The following is a description of a gene set: part of: GPCR downstream signalling electronically inferred by orthology from the curated human pathway species: Mus musculus This event has been computationally inferred from an event that has been demonstrated in another species.<p>The inference is based on the homology mapping from PANTHER. Briefly, reactions for which all involved PhysicalEntities (in input, output and catalyst) have a mapped orthologue/paralogue (for complexes at least 75% of components must have a mapping) are inferred to the other species. Reactome Pathway: G alpha (12/13) signalling events, and this is the list of marker genes: Gng3, Arhgef10l, Gnb2, Gng5, Prex1, Gng10, Arhgef3, Adra1a, Arhgef10, Gng11, Arhgef38, Gng4, Fgd2 (FYVE, RhoGEF and PH domain containing 2), Arhgef17, Arhgef39 (NCBI Gene Id 230098), Arhgef12, Gng7, Gnb5 (NCBI Gene Id 14697), Gna12, Arhgef7, Tbxa2r, Arhgef33, Arhgef1, Arhgef37, Fgd1, Gna13, Rhob, Gngt2, Sos2, Arhgef15, Gngt1, Gng8, Itsn1, Vav1, Ngef, Gnb3